The following is a description of a gene set: species: Mus musculus Cytokines mediate cell-cell communication in the immune system and represent important therapeutic targets. A myriad of studies have highlighted their central role in immune function, yet we lack a global view of the cellular responses of each immune cell type to each cytokine. To address this gap, the authors created the Immune Dictionary, a compendium of single-cell transcriptomic profiles of more than 17 immune cell types in response to each of 86 cytokines (>1,400 cytokine-cell type combinations) in mouse lymph nodes in vivo. A cytokine-centric view of the dictionary revealed that most cytokines induce highly cell-type-specific responses. For example, the inflammatory cytokine interleukin-1β induces distinct gene programmes in almost every cell type. A cell-type-centric view of the dictionary identified more than 66 cytokine-driven cellular polarization states across immune cell types, including previously uncharacterized states such as an interleukin-18-induced polyfunctional natural killer cell state. Genes negatively differentially expressed in cell type: γδ T cell upon treatment with cytokine: IL-4 in mouse lymph nodes in vivo. Mouse Gene Set: CUI_T_CELL_GD_IL4_RESPONSE_DN from publication Cui A, Huang T, Li S, Ma A, Pérez JL, Sander C, Keskin DB, Wu CJ, Fraenkel E, Hacohen N (PMID 38057668), and this is the list of marker genes: Btg2 (BTG anti-proliferation factor 2), S1pr1, Stk17b, Junb, Btg1, Crip1, Neurl3, S100a10, Dgka, Vim, Nr4a1, Klf6, Emp3, Tspo, Dusp1, Klf2, Itgb7, Add1, Ubc, Emb, Cdkn2d, Cd3g, Lsp1